The following is a description of a gene set: studied in species Homo sapiens CD4+ T helper lymphocytes that express interleukin-17 (Th17 cells) have critical roles in mouse models of autoimmunity, and there is mounting evidence that they also influence inflammatory processes in humans. Genome-wide association studies in humans have linked genes involved in Th17 cell differentiation and function with susceptibility to Crohn’s disease, rheumatoid arthritis, and psoriasis1-3. Thus, the pathway towards differentiation of Th17 cells and, perhaps, of related innate lymphoid cells with similar effector functions4, 5, is an attractive target for therapeutic applications. Mouse and human Th17 cells are distinguished by expression of the retinoic acid receptor-related orphan nuclear receptor RORγt, which is required for induction of IL-17 transcription and for the manifestation of Th17-dependent autoimmune disease in mice6. By performing a chemical screen with an insect cell-based reporter system, we identified the cardiac glycoside digoxin as a specific inhibitor of RORγt transcriptional activity. Digoxin inhibited murine Th17 cell differentiation without affecting differentiation of other T cell lineages and was effective in delaying the onset and reducing the severity of autoimmune disease in mice. At high concentrations, digoxin is toxic for human cells, but non-toxic synthetic derivatives, 20,22-dihydrodigoxin-21,23-diol (Dig(dhd)) and digoxin-21-salicylidene (Dig(sal)), specifically inhibited induction of IL-17 in human CD4+ T cells. Using these small molecule compounds, we demonstrated that RORγt is imporant for the maintenance of IL-17 expression in mouse and human effector T cells. These data suggest that derivatives of digoxin can be used as chemical probes for development of RORγt-targeted therapeutic agents that attenuate inflammatory lymphocyte function and autoimmune disease. from publication Huh JR, Leung MW, Huang P, Ryan DA, Krout MR, Malapaka RR, Chow J, Manel N, Ciofani M, Kim SV, Cuesta A, Santori FR, Lafaille JJ, Xu HE, Gin DY, Rastinejad F, Littman DR (PMID 21441909) Genes up-regulated in polarizing CD4 Th17 cells treated by digoxin: wildtype versus RORC knockout. Human Gene Set: GSE27241_WT_VS_RORGT_KO_TH17_POLARIZED_CD4_TCELL_TREATED_WITH_DIGOXIN_UP, and this is the list of marker genes: ARID1A, ST8SIA1, USP37, ATP13A3, CREBBP, SP1, TMEM94, TTC7B, SMC2, SETD2, PRPF8, RB1, FANCC, UBE4B, PPM1E, H2BC26, ULK1, ATG2B, FCHSD2, CNNM1, IQGAP2, IWS1, RPL11, TLN1, KANSL1, DOCK8, KRTAP1-4, KIF15, PRKCA, SMC1A, TULP4, BAZ2A, MAST2, KIF21B, UBAP2, USP9X, BPTF, NCOR1, ZBTB40, PKM, BRCA1, NUCKS1, POLE, PIK3CG (phosphatidylinositol-4,5-bisphosphate 3-kinase catalytic subunit gamma), MAP4K4, WRN, UTRN, ATAD2, FASN, ATP8A1, ZHX3, DYRK1B, PIK3CD, EP300, CEP350, CHD7, NFAT5, RALGAPA1, ERN1, PPP1R10, GTF3C1, DEPDC5, KMT2B, CDC25B, NPEPPS, KHSRP, CLIC4, NCAPD2, RALGAPA2, TSC2, BLTP1, LMO4, YEATS2, FRYL, ATF7IP, RIC1, CHDH, WDR83OS, ZEB1, PRRC2C, VWA3B, VPS13C, SLC37A3, SRGAP3, TICRR, ARAP2, TET2, USP24, NUP205, GPR25, PSMD11, TAOK1, KAT7, WNK1, PCM1, HERC1, RPS27A, TBCEL, TMEM245, SOS1, DOCK11, BMPR2, NEURL1B, CORO2B, GXYLT1, KNTC1 (NCBI Gene Id 9735), RPGRIP1L, ZNF106, TRIM26, TBCK, STIL, TNKS, SLC9A9, KIF14, SIPA1L1, ZBTB37, PPP1R12B, SF3A1, CEP104 (NCBI Gene Id 9731), TNFRSF10B, CELSR2, ATM, CKAP5, TUT4, PWWP3B, FNDC3A, ADSS1, CENPC, MYO9B, MACF1, SMG1, BARD1, NME2, TOX2, KMT2C, PHACTR4, ESPL1, NF1 (NCBI Gene Id 646021), TRIM33, ERC1, BAZ1B, KLHL18 (kelch like family member 18), PRCC (proline rich mitotic checkpoint control factor), THRB, SUFU, ASXL1, RFX7 (regulatory factor X7), TTLL4, MIR383, MED13, MYO10 (myosin X), CNNM4, FAM163B, HCFC1, MED12L, ZFP36L2, OTOS, KDM2A, PELP1, ATP2A2, RIF1, PITPNC1, ATAD2B, FAM120A, SPRY3, RAD21, NSD2, CAMK1D, BIRC6, GBF1, SMARCD1, PRR14L, XYLT2, RHOBTB2, NBEAL1, IL17RB, CNOT6L, SBNO1, PRDM10, BLTP3B